Given this list of marker genes NXPH4, MYO1E, NOVA2, NTRK1, FOXC2, RHOV, MUSK, RYR2, CHIT1, ZBTB7A, MAP1A, EMC3, here is a description of the gene set: Left ventricular mass (LVM) and cardiac gene expression are complex traits regulated by factors both intrinsic and extrinsic to the heart. To dissect the major determinants of LVM, we combined expression quantitative trait locus1 and quantitative trait transcript (QTT) analyses of the cardiac transcriptome in the rat. Using these methods and in vitro functional assays, we identified osteoglycin (Ogn) as a major candidate regulator of rat LVM, with increased Ogn protein expression associated with elevated LVM. We also applied genome-wide QTT analysis to the human heart and observed that, out of 22,000 transcripts, OGN transcript abundance had the highest correlation with LVM. We further confirmed a role for Ogn in the in vivo regulation of LVM in Ogn knockout mice. Taken together, these data implicate Ogn as a key regulator of LVM in rats, mice and humans, and suggest that Ogn modifies the hypertrophic response to extrinsic factors such as hypertension and aortic stenosis. Human Gene Set: PETRETTO_BLOOD_PRESSURE_UP studied in species Rattus norvegicus from publication Petretto E, Sarwar R, Grieve I, Lu H, Kumaran MK, Muckett PJ, Mangion J, Schroen B, Benson M, Punjabi PP, Prasad SK, Pennell DJ, Kiesewetter C, Tasheva ES, Corpuz LM, Webb MD, Conrad GW, Kurtz TW, Kren V, Fischer J, Hubner N, Pinto YM, Pravenec M, Aitman TJ, Cook SA (PMID 18443592) Genes that are most strongly positively correlated with systolic blood pressure (SBP).